The following is a description of a gene set: studied in species Mus musculus Mouse genes annotated to increased incidence of tumors by ionizing radiation induction (MP:0004500) retrieved from the Mouse Genome Informatics database via MouseMine Mouse Gene Set: MP_INCREASED_INCIDENCE_OF_TUMORS_BY_IONIZING_RADIATION_INDUCTION from publication Motenko H, Neuhauser SB, O'Keefe M, Richardson JE (PMID 26092688), and this is the list of marker genes: Bin3, Cdc25a, Rpl11, Pten, Cdkn2a, Gadd45a, Trp53bp2, Trp53, Mtf1, Brca1 (breast cancer 1, early onset), Ptch1, Uimc1, Per2, Rassf1, Hmgn1, Cdkn1a (NCBI Gene Id 12575), Nbn